Given this list of marker genes RUNX3, EBAG9, OPTN, PPP1CA, ARL1, PSMG1, LRPAP1, CILK1, PRKCSH, CELSR2, LY6E, P4HB, PYCR1, EEF1D, KLHL21, DDB2, NDUFS8, PPIB, FOXO3, PTPRN2, NINJ1, POLR2K, BCL3, HSPA13, CREG1, SNRPD1, BST2, INO80B, EXOSC4, RNF114, here is a description of the gene set: Genes down-regulated in C666-1 cells (nasopharyngeal carcinoma) by stable expression of RASSF1. species: Homo sapiens from publication Chow LS, Lam CW, Chan SY, Tsao SW, To KF, Tong SF, Hung WK, Dammann R, Huang DP, Lo KW (PMID 16116475) RASSF1A is a tumor suppressor gene on 3p21.3 frequently inactivated by promoter hypermethylation in nasopharyngeal carcinoma (NPC). To identify RASSF1A target genes in NPC, we have investigated the expression profile of the stable RASSF1A transfectants and controls by high-density oligonucleotide array. A total of genes showed differential expression in the RASSF1A-expressing cells. These RASSF1A target genes were involved in multiple cellular regulatory processes such as transcription, signal transduction, cell adhesion and RNA processing. The RASSF1A-modulated expression of eight selected genes with the highest fold changes (ATF5, TCRB, RGS1, activin betaE, HNRPH1, HNRPD, Id2 and CKS2) by RASSF1A was confirmed in both stable and transient transfectants. Compared with the RASSF1A transfectants, an inverse expression pattern of activin betaE, Id2 and ATF5 was shown in the immortalized nasopharyngeal epithelial cells treated with siRNA against RASSF1A. The findings imply that the expression of activin betaE, Id2 and ATF5 was tightly regulated by RASSF1A and may associate with its tumor suppressor function. Strikingly, overexpression of Id2 is common in NPC and RASSF1A-induced repression of Id2 was mediated by the overexpression of activin betaE. The results suggest a novel RASSF1A pathway in which both activin betaE and Id2 are involved. Human Gene Set: CHOW_RASSF1_TARGETS_DN